Given this list of marker genes SHC1, NTRK3, NRAS, KRAS (KRAS proto-oncogene, GTPase), SOS1, NTF3, HRAS, GRB2, here is a description of the gene set: studied in species Homo sapiens Activated NTRK3 signals through RAS Human Gene Set: REACTOME_ACTIVATED_NTRK3_SIGNALS_THROUGH_RAS